Given this list of marker genes Washc1, Septin1, Mei1, Ska2, Cenpe (centromere protein E), Aurka, Ndc80, Golga2, Atrx, Pten, Myh9, Ska3, Espl1, Ddb1, Tubg2, Dcaf13, Ska1, Tubg1, Ccnb2, Washc5, Dicer1, Mos, Ppp2r1a, Aspm, Fbxo5, here is a description of the gene set: Mouse Gene Set: GOBP_MEIOTIC_SPINDLE_ORGANIZATION studied in species Mus musculus A process that is carried out at the cellular level which results in the assembly, arrangement of constituent parts, or disassembly of the microtubule spindle during a meiotic cell cycle.